Given this list of marker genes NOTCH1, ONECUT1, MAML3, SNW1, KAT2A, MAML2, KAT2B, HES1, CREBBP, EP300, ONECUT3, MAMLD1, NEUROG3, HNF1B, MAML1, RBPJ, here is a description of the gene set: species: Homo sapiens Regulation of gene expression in late stage (branching morphogenesis) pancreatic bud precursor cells Human Gene Set: REACTOME_REGULATION_OF_GENE_EXPRESSION_IN_LATE_STAGE_BRANCHING_MORPHOGENESIS_PANCREATIC_BUD_PRECURSOR_CELLS